Given this list of marker genes Gpr137b, Bcl11a, Tnfrsf13c, Pank2, Tespa1, Ms4a1, Mical1, Pik3ap1, Cd22, Smad1, Lmo2, Rel, Cd83, Klhl6, Gpatch2l, Smim14, Bmp2k, Tpm4, Tspyl3, Il4i1, Elk3, Bach2, Cd40, Tlr1, Dtx1, Laptm5, Mta3, Spib, Cotl1, Ablim1 (NCBI Gene Id 72478), Cpm, Calm2, Srpk3, Anp32a, Arpc5l, Lrch1, here is a description of the gene set: from publication Mori S, Rempel RE, Chang JT, Yao G, Lagoo AS, Potti A, Bild A, Nevins JR (PMID 18922927) Mouse Gene Set: MORI_PLASMA_CELL_DN Down-regulated genes in the B lymphocyte developmental signature, based on expression profiling of lymphomas from the Emu-myc transgenic mice: plasma cell. The Emu-myc transgenic mouse has provided a valuable model for the study of B-cell lymphoma. Making use of gene expression analysis and, in particular, expression signatures of cell signaling pathway activation, we now show that several forms of B lymphoma can be identified in the Emu-myc mice associated with time of tumor onset. Furthermore, one form of Emu-myc tumor with pre-B character is shown to resemble human Burkitt lymphoma, whereas others exhibit more differentiated B-cell characteristics and show similarity with human diffuse large B-cell lymphoma in the pattern of gene expression, as well as oncogenic pathway activation. Importantly, we show that signatures of oncogenic pathway activity provide further dissection of the spectrum of diffuse large B-cell lymphoma, identifying a subset of patients who have very poor prognosis and could benefit from more aggressive or novel therapeutic strategies. Taken together, these studies provide insight into the complexity of the oncogenic process and a novel strategy for dissecting the heterogeneity of B lymphoma. species: Mus musculus